The following is a description of a gene set: part of: Biological oxidations Reactome Pathway: Phase II - Conjugation of compounds species: Homo sapiens Phase II of biotransformation is concerned with <b><i>conjugation</i></b>, that is using groups from cofactors to react with functional groups present or introduced from phase I on the compound. The enzymes involved are a set of transferases which perform the transfer of the cofactor group to the substrate. The resultant conjugation results in greatly increasing the excretory potential of compounds. Although most conjugations result in pharmacological inactivation or detoxification, some can result in bioactivation. Most of the phase II enzymes are located in the cytosol except UDP-glucuronosyltransferases (UGT), which are microsomal. Phase II reactions are typically much faster than phase I reactions therefore the rate-limiting step for biotransformation of a compound is usually the phase I reaction.<br>Phase II metabolism can deal with all the products of phase I metabolism, be they reactive (Type I substrate) or unreactive/poorly active (Type II substrate) compounds. With the exception of glutathione, the conjugating species needs to be made chemically reactive after synthesis. The availability of the cofactor in the synthesis may be a rate-limiting factor in some phase II pathways as it may prevent the formation of enough conjugating species to deal with the substrate or it's metabolite. As many substrates and/or their metabolites are chemically reactive, their continued presence may lead to toxicity., and this is the list of marker genes: GSTO1, GSTM4, UGT1A4, MGST2, MTRR (NCBI Gene Id 4552), UGT3A1, GSTT2B, UGT2B10, GSTA5, MGST3, GSTA3, UGT1A10, GSTM2, UGT2B7, UGT1A5, NAT2, UGT2B28, MAT2B, GSTA4, COMT (catechol-O-methyltransferase), SULT1B1, GSTM1, SULT1E1, ACSM1, AKR1A1, UGT1A3, GGT7, SULT2B1, OPLAH, BPNT1, GSTZ1, MAT2A, ACSM2B, ACSM2A, CHAC1, GGT3P, TPMT, SULT6B1, ACSM4, GSS, UGP2 (UDP-glucose pyrophosphorylase 2), UGT1A6, UGT1A1, UGT2B15, GCLC, GGT5, PODXL2, GSTK1 (glutathione S-transferase kappa 1), CYP1A2, MGST1, TPST2, MAT1A, SULT1C2, SULT1C4, SULT1A4, CNDP2, TRMT112, GGT6, GSTM3, BPNT2, GCLM, UGT2B11, UGT2A3, UGT1A7 (UDP glucuronosyltransferase family 1 member A7), GSTT1, GLYAT, HEMK2, TPST1, HPGDS, ABHD14B, UGT1A8, UGT3A2, AHCY, GLYATL3, GSTA2, CHAC2, GSTT2, NAT1, AS3MT, SULT1A2, GSTO2 (NCBI Gene Id 119391), ACSM5, GLYATL2, GSTM5, NNMT, SULT1A3, UGDH, SLC35D1, MTR, UGT2B17, UXS1 (NCBI Gene Id 80146), GSTA1, UGT2B4, SULT2A1, UGT2A2, SLC35D2, ESD, UGT2A1, GLYATL1, GGCT, GSTP1, GGT1, ABHD10, UGT1A9, SULT4A1 (sulfotransferase family 4A member 1), SULT1A1